Given this list of marker genes ATP6V0A4, RNASEK, ATP6AP2, ATP6V0A1, ATP6V0E1, ATP6V0D2, ATP6V0E2, ATP6V0C, ATP6V0D1, TCIRG1, ATP6V0A2, ATP6V0B, here is a description of the gene set: A protein complex that forms part of a proton-transporting V-type ATPase and mediates proton transport across a membrane. The V0 complex consists of at least four different subunits (a,c,d and e); six or more c subunits form a proton-binding rotor ring. studied in species Homo sapiens Human Gene Set: GOCC_PROTON_TRANSPORTING_V_TYPE_ATPASE_V0_DOMAIN